Given this list of marker genes NOTCH1, PRF1, STAT3, CUL1, RB1, GZMB, RBX1, MOV10, IRF4, AGO2, FOXM1, AGO4, IL10RA, MAPK1, TNRC6C, HDAC1, SKP1, MAPK3, TWIST1, MIR21, STAT5A, ZAP70 (NCBI Gene Id 7535), JUNB, NPM1, DNMT1, CCNB1, MECP2, PTPN6, BCL2A1, RPS6, ICOS, CEBPB, AGO3, AGO1, ZC3HC1, here is a description of the gene set: Signaling through oncogenic forms of ALK activate nuclear events that drive cellular survival, escape from apoptosis and transformation. Changes to gene expression are effected both by epigenetic mechanisms and by inducing expression of key transcription factors and cell cycle regulators, among other critical targets. Many of these gene expression events are dependent on activation of STAT3 and to a lesser extent, MAP kinase signaling downstream of ALK. Unique among fusion proteins identified to date, the well-studied NPM-ALK fusion appears to be partially localized to the nucleus by virtue of oligomerization with endogenous full-length NPM. part of: Signaling by ALK fusions and activated point mutants Reactome Pathway: Nuclear events stimulated by ALK signaling in cancer studied in species Homo sapiens